Given this list of marker genes Cybb, Ikbke (inhibitor of kappaB kinase epsilon), AA467197 (expressed sequence AA467197), Prdx5, Upp1, Acod1, Cd14, Nfkbia, Chi3l1, Fpr2, Plac8, Cxcl2, Rab20, Wfdc21, Fth1, Marcksl1, Vasp, Ctsb (NCBI Gene Id 210034), Icam1, C3, Ehd1, Mapkapk2, N4bp1, Bcl2a1a, Cyfip1 (NCBI Gene Id 29878), Lcn2, Dusp16, Sod2, Samsn1, Il1rn, here is a description of the gene set: from publication Cui A, Huang T, Li S, Ma A, Pérez JL, Sander C, Keskin DB, Wu CJ, Fraenkel E, Hacohen N (PMID 38057668) species: Mus musculus Genes positively differentially expressed in cell type: Neutrophil upon treatment with cytokine: TNF-α in mouse lymph nodes in vivo. Cytokines mediate cell-cell communication in the immune system and represent important therapeutic targets. A myriad of studies have highlighted their central role in immune function, yet we lack a global view of the cellular responses of each immune cell type to each cytokine. To address this gap, the authors created the Immune Dictionary, a compendium of single-cell transcriptomic profiles of more than 17 immune cell types in response to each of 86 cytokines (>1,400 cytokine-cell type combinations) in mouse lymph nodes in vivo. A cytokine-centric view of the dictionary revealed that most cytokines induce highly cell-type-specific responses. For example, the inflammatory cytokine interleukin-1β induces distinct gene programmes in almost every cell type. A cell-type-centric view of the dictionary identified more than 66 cytokine-driven cellular polarization states across immune cell types, including previously uncharacterized states such as an interleukin-18-induced polyfunctional natural killer cell state. Mouse Gene Set: CUI_NEUTROPHIL_TNFA_RESPONSE_UP